The following is a description of a gene set: Mouse Gene Set: REACTOME_HIGH_LAMINAR_FLOW_SHEAR_STRESS_ACTIVATES_SIGNALING_BY_PIEZO1_AND_PECAM1_CDH5_KDR_IN_ENDOTHELIAL_CELLS High laminar flow shear stress activates signaling by PIEZO1 and PECAM1:CDH5:KDR in endothelial cells studied in species Mus musculus, and this is the list of marker genes: Calm3, Gng12, Trpv4, P2ry2, Prkacb, Gng2, Gnb1, Akt1, Calm2, Prkar1a, Prkar1b, Gnaq, Pdpk1, Mlst8, Calcrl, Gng10, Adm, Gng13, Vcl, Gnas, Gng11, Gngt2, Gnb4, Capns2 (NCBI Gene Id 69543), Capns1, Prr5, Nos3, Gng8, Rictor, Mtor, Gnb2, Gng5, Capn2, Gnb5, Calm1, Mapkap1, Prkaca, Gngt1, Pkn2, Gng3, Gng4, Gna11, Gnb3, Gng7, Ramp2